The following is a description of a gene set: Human Gene Set: GOBP_ENDOCYTOSIS A vesicle-mediated transport process in which cells take up external materials or membrane constituents by the invagination of a part of the plasma membrane to form a new membrane-bounded vesicle. studied in species Homo sapiens, and this is the list of marker genes: APOA5, NCF2, ATP6V1H, LBP, PRKCE, NEU3, ANXA11, SCYL2 (SCY1 like pseudokinase 2), MARCHF2, MAPKAPK3, C2, ITGA2, ITCH, GAS7, UNC119, DLG4, GSN, ATG3, FCN1, CALCRL, CALM3, STEAP2, GPR107, MARCHF3, ITGAM, LDLRAP1, PLD4, VEGFA, MCTP1, BTK, PDLIM7, FLOT1, AP3S2, RAB14, BIN2, ABCA7, FNBP1L (NCBI Gene Id 54874), CD63, PIP5K1A, TIMD4, DNER, MAGI2, TLR2, CDC42SE1, SDCBP, MIB1, MBL2, ARHGAP27, ARF6, APP, TGM2, JOSD1, SLAMF1, KIAA0319L, TREM2, ITGB1, SPON2, RAMP1, SDC1, RAB9B, IL15RA, LRP3, ANKRD13B, MYO1B, GRB2, SLC9B2, DOCK1, DOCK2, C4A, RAB34 (RAB34, member RAS oncogene family), FCHO2, LGALS3, CDC42, CEBPE, MYO1G, DKK1, XKR7, OCIAD2, BIN3, STAB1, VAV1, PSTPIP1, DNAJC6, VAC14, RAP1GAP, TNK2 (NCBI Gene Id 10188), MIR205, SH3BP1, PI4KB (phosphatidylinositol 4-kinase beta), AP2B1, ADRB2 (adrenoceptor beta 2), LRSAM1 (leucine rich repeat and sterile alpha motif containing 1), STAP1, LEP, IFNG, MYO18A, MFGE8, SYNRG, SHH, ARRB2, EHBP1, RAB5C, MYO19, ITGB2, KCNQ3, OPHN1, AXL, HMGB1, STX1A, MRC2, YES1, LRP4, CDK5, SCAMP1, PLLP, DNAJC13 (NCBI Gene Id 285196), TOM1, AZU1, TF, CXCL16, ADGRB1, HEATR5B, DGKQ, CBLL1, EQTN, EPN1, CSK, SUSD4 (NCBI Gene Id 55061), DPP4, SNCB, PEAR1, PACSIN3, LYST, PPT1, GAK, BMP2K, SOD1, CYBA, RAB4B, CTBP1, SAG, HEATR5A, SCAMP5, ICAM3 (NCBI Gene Id 3385), CRYBA1, CARMIL1, RAB4A, WNT5A, RABGEF1, APELA, PROM2, CCR7, RACK1, APLP1, FMR1, LMBR1L, PIK3C3, CREG1, SIGLEC1 (sialic acid binding Ig like lectin 1), SGIP1, LYVE1, DENND1A, SYNJ1, SRPX, EPN3 (epsin 3), IL15, RALB, IGF2R, MYO15A, CD177, RAMP3, NCKIPSD, ADIPOQ, CLIP3, TICAM2, APOC3, DNM1L, C3, ARC, RNF220, EPHA3, EIF2AK1, MYO7A, RALA, RABEP2, F2RL1, MAPK1, DLL1, RUFY1, NLGN1, PTPRJ, LILRB1, DBNL, WDR54, NDP, PIP5K1C, EEF2K, CXCR2, BLTP1, FCN3, APOC2, HPCA, UNC13D, TPCN2, RAB9A, SYT11, AP3S1, SPACA3, MYO1H, RARA, BCR, SH3GL2, ASGR2, SIRPG, SH3KBP1, MKLN1, CEACAM4, SIRPA, CD93, NOSTRIN, RUBCN, NTF3, CLEC4F, MYO1C, RHOV, BICD1, SNX5, GRK3, ITSN2, TREX1, DENND1C, RAB15, HAMP, USP6, SH3GL1, RAB7A, CLEC7A, IRF8, CLCN5, CAPN2, CD36, ADRB3, FPR2, CLCN3, LRP5, AHSG, ITGB3, PRKD1, AP3M1, APPL2 (NCBI Gene Id 55198), VAV3, FGR, AP3M2, CCR2, GAS6, APLNR, MTMR2, TULP1, FCGR2B, DYSF, CLINT1, AHI1, SERPINE1, PRKCD, CAV1, TFRC, DAB2, GRK4, CLTCL1, DMBT1, ANKRD13D, EZR, SYT7, BTBD9, NEURL3, STON2, ESYT2, EHD4, EPS15, SORT1, VAV2, PICALM, ARHGAP25, AP3D1, NLGN3, CSNK1G3, SFTPD, BCL2L1 (BCL2 like 1), RAB22A, GHR, CTSL, RSPO1, VIPAS39 (NCBI Gene Id 63894), INSR, TRIP10, AIF1, EHD1, DPYSL2, PIK3CG, INPPL1, SORL1, SMPD1, CALCA, EHD3, CTTN, CD22, CALR, SPG11, RAB20, LILRB4, RAP1A, FNBP1, JMJD6, ACTG1, PTPN1, TBC1D24, PARK7, RAB5A, GULP1, SIRPB1, DRD2, VAMP2, USP33, STAB2, AMN, SNX12 (sorting nexin 12), SNX10, ADORA2A, NOS2, LIMK1, RAB39A, CAV2, CD14, NECAP2, SYP, LRP8, ANXA2P2, MLC1, ARR3, LY75, MICALL1, CD47, RAB1A, XKR4, MIR17, FCMR, CD151, COLEC10, STON1, LRP2, RHOJ, COLEC12, CORO1C, TBC1D2B, INPP5F, LETMD1, CNTN2, SYT4, CLTB, MIR185, MESD, CLEC4M, P2RY6, CFP, TM9SF4, P2RX7, AP2A2, MIR183, LPAR1, TYROBP, ZFYVE9, LRP1, RAB5B (RAB5B, member RAS oncogene family), PRKACA, NCF4, FCGR2C, LRRK2, MAPKAPK2, PLCG2, ELMO1, GTF2H2, RIT2, VPS33B (VPS33B late endosome and lysosome associated), ACTB, MYO5A, CAV3, SFTPA1, SPHK1, SCARB2, MIR27B, CAMK1D, CLTC, NME1, MYD88, APOA2, PLXNB2, ADORA1, EGF, ABCA1, IL2RG (interleukin 2 receptor subunit gamma), SNAP91, ITGA4, ATP9A, ANXA2 (annexin A2), ACKR3, MTMR9, FKBP15, PRKCG (NCBI Gene Id 57013), ANO6, MX1, CDC42SE2, HCK, LRRTM2, CALM2, LRP12, NEDD4, PPP3CA, MYO1E, CXCR1, ANXA3, SNX1, MYO1D, GPC3, MIR20A, C9orf72, DNM3, AGER, PIP4P2, MYO5B, MYH9, ARPC3, FCER1G, BTBD8, SCARA5, APOC1 (apolipoprotein C1), PLPP4, NEDD4L, ARRB1, HSPG2, PRKN, FCN2, ANKFY1, REPS1, FCHO1, MYO6 (myosin VI), SYNJ2BP, USP20, WASL, HGS, MYO1F, EEA1, PIK3CB, THBS1, ITGAL, VPS28 (NCBI Gene Id 51160), TYRO3, ASGR1, MX2, CD81, VAMP7, TMEM108, SNX3, CLEC9A, NR1H2, TMEM175, NCKAP1L, NCDN, C4B, PPP3CC, ABCA2, ARF1, ROCK1, PTK2, AMPH, CD302, AP2A1, RABEP1, BIN1, CBL, LDLR, RAC1, CAP1, ENTHD1, PYCARD, TSG101, CANX, OPA1, BECN1, RAB21, PLD2, STAT3, MIR181B1, FOLR1, MIR199A1, LMAN2, ARL8B, RALBP1, PECAM1, TGFB1, VAMP4, AP2S1, ALOX15, STX1B, RNASEK, IGHE, ANXA1, CLCN2, RINL, RAB11FIP2, MEGF10, NUMB, GATA2, MST1R, MDM2, AP2M1, CSNK1G1, CCL21, B2M, VLDLR (very low density lipoprotein receptor), SNCA, APPL1, PPP3R1, ELMO2, USH1G, MRC1, SLC48A1, RAB27B, LYN, SCARB1, AAK1, TAMALIN, C1orf43, GSG1L, RABGAP1L, KCNN4, RABEPK, HMMR, ANGPT1, NPC1, SNX9, IL2RB, DNM2, ATP8A1, GH1 (NCBI Gene Id 2688), TSC2, ARFGAP1, SH3BP4, GRIA1, APLN, LRP10, CLTA, SYK, IL4, SNX18, RHOQ, XKR8, ABL2, PIK3CA, MYO7B, ELMO3, PTPRC, IL10RA, CSNK1G2, AP1S1, DRD4, MTMR6, PLA2G5, ELANE, FCGR1BP (Fc gamma receptor Ib, pseudogene), RUFY2, LMBRD1, RHOU, TFR2, ANKRD13A, PRTN3, DTNBP1, HIP1R, EPN2, ITSN1, FYN, PAK1, CALY, SNCG, DENND1B, HIP1, M6PR (mannose-6-phosphate receptor, cation dependent), PTX3, RIN2 (Ras and Rab interactor 2), UBE3A, CD300A, MYLK, SLC17A7, CUBN, DRD3, C4BPB, ICAM5, EHD2, MSR1, PLSCR1, ZFYVE16, RIN3, GAPVD1, SYNJ2, CD9, NECAB2, SNX33, C4BPA, VTN, LDLRAD3, SRC, FCGR2A, LRRTM1, CD300LF, CD209, ANK2, LEPR, CBLB (Cbl proto-oncogene B), COLEC11, TUSC2, LRP1B, MAPK3, CALM1, ADM, ATG5, CRP, MIR92B, TUB, TBC1D5, OCIAD1, LRPAP1, ATAD1, SELE, LRP6, CLN3, XKR6, PACSIN2, ABL1, MYCBPAP, MYO1A, CSNK1E, PIK3C2A, CXCL8, EFNB2, HAVCR1, SYT17 (NCBI Gene Id 51760), WASF2, PPP3CB, CCDC32, HRAS, UBQLN2, CSNK1D, CLU, APOE, ARHGAP12, RAMP2, PACSIN1, GREM1, PIKFYVE, MERTK, LIPA, H1-1, APOA1, SLITRK1, ATXN2, PLA2R1, ATP9B, DGKD, TOR1A, SLC2A4, CEACAM1, FCER2, ITGAV, HOOK2, CCL2, LYAR, RAB27A, PCSK9, ABCA13, NEURL1B, CYTH2, GRK2, SH3GL3, SMAP1, AP1G1, SCARF1, SCRIB, RAB31, CCL19, CORO1A, PICK1, ENTREP1, AP3B2, FCHSD2, DNM1, USP46, SLC11A1, EPS15L1, NECAP1, CDH13, NRG1, NR1H3, WASF1, TLR4, ARAP1, MYO5C, HFE, ACHE, CLEC10A, RAB7B, REPS2, CNN2, TAFA4, WNT3A, PLA2G6, ACE2, RIN1, SNX17, MARCO, SFRP4, FCGR1A